Given this list of marker genes COL17A1, ANXA13, CNOT2, CSF1R, ESAM, EMSY, DNAJB4, ATPAF1, TNS1, SASH1, WDFY2, APOBEC1, SDC4, GEM, DHX34, ZMYND11, RGS12, RHOH, MYOZ1, CRBN, CASP4, SLFN13, POU6F1, TDP1 (tyrosyl-DNA phosphodiesterase 1), CDH17, SLC16A7, IFIT2, SLC6A12, LAMTOR1 (NCBI Gene Id 55004), ANP32A, SQOR, ASCC1, NRBF2, GFI1, KRT80, SNAPC5, CEP83-DT, FOXO3, GPRASP3, AP1S2, GGH, FOSL2, MMD, MZF1, SASH3, KLRG1, TASL, ST8SIA6, GDAP1, CD164L2, PPP1R14A, MEGF6, MYCBP2, NAB1, ADAMDEC1, GPR183, STARD3, RNASEL, LGALS8, ILF2, ESR1, NXPE2, KLF13, AGRN, PLAU, ANKRD37, ZCCHC10, HECTD2, SCN2B, SPATS2, CCDC112, SFXN2, ATRNL1 (NCBI Gene Id 26033), RASAL1, PTPN6, PTK2B, ANKH, SNHG10, TEX9, HEXIM2, MDFI, NPC1, PGLYRP2, EFEMP1, KCNIP3, SSC5D, DENND3, GART, FABP5, PRCD, DEGS1, MID2, ZAN (NCBI Gene Id 7455), RAC2, ZNF471, HIC1, TNFSF10, CYBB, EFNA1, UBE2E2, HAO2, CTC1, LYST, ZNF239, CEP83, PTGER3, HCAR2 (NCBI Gene Id 338442), TMEM86A, FBXW10, TRPT1, ARHGAP9, TRPM1, IKBKB, IFT80, HAUS8, PREX1, CCR6, CREBL2, SPNS3, HROB, C2orf80, CLEC4G (NCBI Gene Id 339390), SMPD2, LYPLA2, SLC16A14, ABCB4, SNX16, NFS1, DGCR8, XPC, CD300A, DRAM1, ZNF777, DDX47, TNFRSF11A, GDPD3, POU2F2, FAM111A, STK10, REC8, TENT5A, REV1, WNT10A, FOXN3, ZNF493, ELMOD3, KCNJ16, PILRA, CD276 (CD276 molecule), PPP1R3D, PIGH, SLC44A2, DNAJA4, MAPK11, RASGEF1B, ST6GALNAC3, PIWIL2, GSG1, HMG20A, GNL2, CLEC12B, PCYT1A, SPATA4, HAL, CIAO2A, BBS9, RAD51C, GPRC5D, CASP1, API5, AKAP12, ARRB2, TMEM273, ACKR1, PTS, ABCG2, KLHDC1, FRMD5, MTARC1, BIK, TBC1D4, SLC7A7, LRRC17, KNOP1, RIN2, GGT5, H2AZ1, TEF, DSCAM (DS cell adhesion molecule), RPS6KA1, SYT7, AFG1L, VEGFC, TOX, MLH1, HLA-DMB, INPP5F, SLC37A2, SIRPA, UBL3, here is a description of the gene set: studied in species Homo sapiens Genes down-regulated in day 7 memory B cells versus day 7 germinal center B cells. To obtain insight into the genetic basis of the increase of functional activity of memory B cells over time, we compared the gene expression profiles of day 7 and day 40 NP-specific/IgG1 memory B cells, GC B cells and plasma cells in immunized WT mice and naïve B cells, before and after activation in vitro. from publication Kaji T, Ishige A, Hikida M, Taka J, Hijikata A, Kubo M, Nagashima T, Takahashi Y, Kurosaki T, Okada M, Ohara O, Rajewsky K, Takemori T (PMID 23027924) Human Gene Set: GSE11961_MEMORY_BCELL_DAY7_VS_GERMINAL_CENTER_BCELL_DAY7_DN